Given this list of marker genes PGLYRP1, PGLYRP2, PGLYRP3, PGLYRP4, CD14, here is a description of the gene set: Human Gene Set: GOMF_PEPTIDOGLYCAN_IMMUNE_RECEPTOR_ACTIVITY Combining with a peptidoglycan and transmitting the signal to initiate an innate immune response. species: Homo sapiens